Given this list of marker genes MC1R (NCBI Gene Id 4157), POLA1, ACTR5, XPC, H2AC25, SIRT1, TREX1, POLD3, DDB2, XPA, INO80, CUL4B, DDB1, ERCC1, here is a description of the gene set: A DNA repair process that is initiated by an endonuclease that introduces a single-strand incision immediately 5' of a UV-induced damage site. UV-damage excision repair acts on both cyclobutane pyrimidine dimers (CPDs) and pyrimidine-pyrimidone 6-4 photoproducts (6-4PPs). studied in species Homo sapiens Human Gene Set: GOBP_UV_DAMAGE_EXCISION_REPAIR